The following is a description of a gene set: Human Gene Set: GOMF_DEHYDROASCORBIC_ACID_TRANSMEMBRANE_TRANSPORTER_ACTIVITY Enables the transfer of dehydroascorbate, 5-(1,2-dihydroxyethyl)furan-2,3,4(5H)-trione, from one side of a membrane to the other. studied in species Homo sapiens, and this is the list of marker genes: SLC23A1, SLC2A3, SLC2A14, SLC2A1, SLC2A8, SLC2A10, SLC2A2, SLC2A6